Given this list of marker genes SRF, ELK1 (ETS transcription factor ELK1), CDK5, KRAS, RAF1, RAP1A, MEF2C, PRKCD, NTF3, TRPV1, FOS, EHD4, MAPK7, MAPKAPK2, MAP2K1, MAP2K6, EGR1, MAP3K2, RPS6KA1, BRAF, CDK5R1, RPS6KA5, MAPK3, MAPK14, RIT1, RIT2, RUSC1, RAP1B, MAPK1, NRAS, MAP2K3, CREB1, HRAS, MAP2K5, here is a description of the gene set: Trk receptor signaling mediated by the MAPK pathway species: Homo sapiens Human Gene Set: PID_MAPK_TRK_PATHWAY from publication Schaefer CF, Anthony K, Krupa S, Buchoff J, Day M, Hannay T, Buetow KH (PMID 18832364)